The following is a description of a gene set: species: Homo sapiens from publication Zhang W, Ferguson J, Ng SM, Hui K, Goh G, Lin A, Esplugues E, Flavell RA, Abraham C, Zhao H, Cho JH (PMID 22715389) In this study, we examined differential gene expression in naïve human CD4+ T cells, as well as in effector Th1, Th17-negative and Th17-enriched CD4- T cell subsets. We observed a marked enrichment for increased gene expression in effector CD4+ T cells compared to naive CD4+ among immune-mediated disease oci genes. Within effector T cells, expression of disease-associated genes was increased in Th17-enriched compared to Th17-negative cells. We used microarray to examine the gene expresssion profile and level of human naïve, Th1 and effector T cell subsets. Genes down-regulated in CD4 naïve versus Th17 enriched. Human Gene Set: GSE32901_NAIVE_VS_TH17_ENRICHED_CD4_TCELL_DN, and this is the list of marker genes: RLIM, MAEA, ACAP3, PLCXD2, ARF4, STC2, SYPL1, RPL18, ACOT7, ALDH18A1, STX12, FCHO2, PASK, MPHOSPH10 (NCBI Gene Id 10199), TOM1, SLMAP, CAMK4, LRRC8D, CLTC, HERPUD1, HACD2, RABGAP1L, TRIM40, SENP7, BCL2L1, CD79A, TMEM168, POLD4, PLK2, FAF1, SRP72, MED10, DDX6, SLAMF1, TXNIP, ADI1, RAD51B, THEMIS2, PTP4A1, TMEM35A, KDM1A, BCL2L14, ZC3H14, SPATA6, CAPN2, PIK3AP1, EMD, C1orf54, VIPAS39, EBF1, PALS2, CHD1, MIR301B, UBFD1, CASP8, PAX5, EXOC4, TUBB2A, ADCY6, PHYH, KMO, PPP3CA, NFKBIZ, POLR2M, SCAF11, LRSAM1, SEC63, EIF5 (eukaryotic translation initiation factor 5), AMMECR1, PHF6, HSP90AB1, PA2G4, DNAJB9, HDAC1, DGKH, NIPSNAP3B, TRMT2B, RUNDC3B, EIF1AX, SMARCE1 (SWI/SNF related, matrix associated, actin dependent regulator of chromatin, subfamily e, member 1), SLC25A36, XBP1, CCDC18, RETREG1, SCD, MFN1, SDF4, ATF6, HCLS1, LY6D, NRIP1, SMS, H3-3B, PLD4, MCU, DNM1L, LNPEP, EID2, CD24, TIA1, UNK, SLA, TGS1, DAPK1, RHOC, GSTT2, RNF4, PLIN2, ABI1, PPARG, BORCS5, TCF4, MED13, FNBP1, TNFRSF18, PRRX2, PAIP1, CCR7, PLEKHA7, AGPS, FBXL17, ATL2, IPO5, GFOD1, MRE11, CDKN1A, RGS1, HDAC2, SAMSN1, VAMP4, ACSL4, OTUD7B, YTHDF1, ZBTB10, FGGY, GLCCI1, INSRR, ERO1A, MPP1, CFAP144P1, NAV1, RFWD3, HK2, IDE, ATRX, MTMR14, RNF125, IREB2, MYO1E, GSPT1, RAB5A, GDE1, SLC27A2, RFT1 (RFT1 homolog), AP3S1, TMEM192, RSF1, WDR36, LARP4, DGAT1, MYO9A (NCBI Gene Id 80251), CD38, SLC43A3, TEX2, FARS2, ERBIN, TJAP1, YPEL5, CCDC50, TRPC4AP, CDYL2, KLF7, CD69, EYA2, STRN3, ADAMTS6, MOSPD1, PRKCH, STAG1